Given this list of marker genes ESAM, ENG, RAMP3, SLC6A4, MT1E, RNASE1, RGCC, ID1, FCN3, IGFBP7 (insulin like growth factor binding protein 7), A2M (NCBI Gene Id 2), HSPG2, NOTCH4, CD93, VWF, CALCRL, CLDN5, FAM107A, LIFR, TNFSF10, CLEC14A, GPX3, MT2A, GNG11, GPIHBP1, CA4, EPAS1, IFNGR1, GIMAP7, HYAL2, EGFL7, MT1X, PECAM1, TCIM, EDN1, SPARC, BTNL9, CAVIN2, IL7R, TM4SF1, IFI27, PLVAP, SPARCL1, PTPRB, AQP1, CD36, MT1M, MGP, RAMP2, TMEM100, here is a description of the gene set: studied in species Homo sapiens from publication Gavish A, Tyler M, Greenwald AC, Hoefflin R, Simkin D, Tschernichovsky R, Galili Darnell N, Somech E, Barbolin C, Antman T, Kovarsky D, Barrett T, Gonzalez Castro LN, Halder D, Chanoch-Myers R, Laffy J, Mints M, Wider A, Tal R, Spitzer A, Hara T, Raitses-Gurevich M, Stossel C, Golan T, Tirosh A, Suvà ML, Puram SV, Tirosh I (PMID 37258682) Genes upregulated in subsets of cells of a given type within various tumors In this study, an extensive analysis was conducted to define meta-programs (MPs) capturing intra-tumor heterogeneity across a spectrum of tumor types. The approach utilized non-negative matrix factorization (NMF) to analyze each cell type separately within individual tumor samples. This involved the analysis of malignant cells, macrophages, fibroblasts, endothelial cells, epithelial cells, T-cells, and B-cells. NMF was executed with varying parameter values (K=4, 5, 6, 7, 8, 9), thereby generating 39 programs for each cell type per sample. Each NMF program was summarized by the top genes based on NMF coefficients.\nRobust MPs were then delineated for each cell type using a set of stringent criteria, including recurrence within the same tumor, similarity to programs in other tumors, and non-redundancy within a tumor. Subsequently, these robust NMF programs were clustered (per cell type) based on Jaccard similarity, leading to the identification of MPs associated with each cell type.\nTo enhance the quality of the MPs, a refinement steps were undertaken, involving the removal of MPs suspected of reflecting low-quality data (with an overrepresentation of ribosomal proteins or mitochondrial-encoded genes), single-study inclusion, or similarity to miss-annotated cell types. Human Gene Set: GAVISH_3CA_METAPROGRAM_ENDOTHELIAL_ENDO_3